Given this list of marker genes GABRA3, COL1A2, PLEC, CACNA1S, PEX1, KCNJ18, KCNJ5, LAMP2, SIL1, MPV17, KCNE3, COL1A1, KCNJ2, PEX6, SCN4A, UBE3B, here is a description of the gene set: Muscle flaccidity studied in species Homo sapiens Human Gene Set: HP_MUSCLE_FLACCIDITY A type of paralysis in which a muscle becomes soft and yields to passive stretching, which results from loss of all or practically all peripheral motor nerves that innervated the muscle. Muscle tone is reduced and the affected muscles undergo extreme atrophy within months of the loss of innervation.